The following is a description of a gene set: Reactome Pathway: Vitamins A number of CYPs can act upon vitamins. species: Homo sapiens part of: Cytochrome P450 - arranged by substrate type, and this is the list of marker genes: CYP27B1, CYP26B1, CYP26A1, CYP26C1, CYP2R1 (NCBI Gene Id 79445), CYP24A1